Given this list of marker genes PRKCE, NFE2L2, AKR7A3, UGT1A10, UGT1A7, here is a description of the gene set: Human Gene Set: GOBP_TOXIN_CATABOLIC_PROCESS The chemical reactions and pathways resulting in the breakdown of toxin, a poisonous compound (typically a protein) that is produced by cells or organisms and that can cause disease when introduced into the body or tissues of an organism. species: Homo sapiens